Given this list of marker genes IGLC2, IGKV3D-20, RCBTB2 (RCC1 and BTB domain containing protein 2), RFLNB, NUCB2, TNFRSF17, TGM2, TPX2, SCAMP5, HBB, CDKN2C, NBPF11, FOS, BHLHA15, VDR, SDF2L1, IGLV3-19, AQP3, ADHFE1, IGHV3-20, NBPF15, CHPF (NCBI Gene Id 79586), HBA2, RRM2, S100A9, ZWINT, AICDA, POU4F1, MYDGF, GOLGA8O, CAV1, PIF1, IGHG1, BLOC1S5-TXNDC5, CXCR3, DCAF12, TXNDC5, SLAMF7, IGHJ2, IGLV3-21, NRGN, IGKV3-7, FNDC3B, DHRS9, XBP1, SDC1, BMP6, NT5DC2, here is a description of the gene set: Human Gene Set: HOEK_B_CELL_2011_2012_TIV_ADULT_7DY_UP from publication Hoek KL, Samir P, Howard LM, Niu X, Prasad N, Galassie A, Liu Q, Allos TM, Floyd KA, Guo Y, Shyr Y, Levy SE, Joyce S, Edwards KM, Link AJ (PMID 25706537) species: Homo sapiens Genes up-regulated in B cell 7d vs 0d in adults after exposure to 2011-2012 trivalent inactivated vaccine (A/California/7/09 (H1N1), A/Perth /16/2009 (H3N2), B/Brisbane/60/2008), time point 7D. Comment: Up-regulated DE RNA transcripts (up >= 1.5x) shared between both TIV-vaccinated donors Systems biology is an approach to comprehensively study complex interactions within a biological system. Most published systems vaccinology studies have utilized whole blood or peripheral blood mononuclear cells (PBMC) to monitor the immune response after vaccination. Because human blood is comprised of multiple hematopoietic cell types, the potential for masking responses of under-represented cell populations is increased when analyzing whole blood or PBMC. To investigate the contribution of individual cell types to the immune response after vaccination, we established a rapid and efficient method to purify human T and B cells, natural killer (NK) cells, myeloid dendritic cells (mDC), monocytes, and neutrophils from fresh venous blood. Purified cells were fractionated and processed in a single day. RNA-Seq and quantitative shotgun proteomics were performed to determine expression profiles for each cell type prior to and after inactivated seasonal influenza vaccination. Our results show that transcriptomic and proteomic profiles generated from purified immune cells differ significantly from PBMC. Differential expression analysis for each immune cell type also shows unique transcriptomic and proteomic expression profiles as well as changing biological networks at early time points after vaccination. This cell type-specific information provides a more comprehensive approach to monitor vaccine responses.